The following is a description of a gene set: Cytosolic tyrosine is transaminated to form 3-(4-hydroxyphenyl)pyruvate which in four further reactions is converted to fumarate and acetoacetate. Tyrosine is thus both a glucogenic (fumarate) and a ketogenic (acetoacetate) amino acid. Defects in any of the steps lead to metabolic diseases with accumulation of tyrosine (tyrosinemia). part of: Phenylalanine and tyrosine metabolism Reactome Pathway: Tyrosine catabolism species: Homo sapiens, and this is the list of marker genes: HGD, FAH, TAT, GSTZ1, HPD